The following is a description of a gene set: Genes predicted to be targets of miRBase v22 microRNA mmu_miR_7009_3p in miRDB v6.0 with MirTarget v4 prediction scores > 80 (high confidence targets). from publication Chen Y, Wang X (PMID 31504780) Mouse Gene Set: MIR_7009_3P species: Mus musculus, and this is the list of marker genes: Dclk1, Banf1, Atxn7, Plpbp, Abcc9, Ddx6, Arid1b, St3gal5, Ankrd27, Actr3, 1700025G04Rik (NCBI Gene Id 98629), Gca, Lcorl, Dennd4a, Ythdc2, Ostc, Kcnt2, Arnt, Arhgap30, Taf7l2, Gatc, Dedd, Frem1, Inpp4b, Kmt2a (NCBI Gene Id 214162), Klhl42 (NCBI Gene Id 635102), Naa50, Larp4, Traf2, Il5, Nrp1, Zc3h18, Arrdc4, Slc1a2, Rxrg (retinoid X receptor gamma), Fgf10 (NCBI Gene Id 14165), Ltbp1, Plpp3, Rxfp3, Tiparp, Kcna6, Sp4, Fzd4, C2cd2, Zfp329, Trhr, Tiam1, Uqcrq, Zfp276 (zinc finger protein (C2H2 type) 276), Tatdn1, Lpp, Mlec, Zfp704, Cckbr, Gpr65, Osbpl6, Prpf4, Cox14, Zic3, Tyw3, Rbm43, Zfp953, Zfp819, Lemd1, Cox7a2l, Spred1, Dock3, Rab6b, Cd83, Cntrl, Nabp2, Mmut, Exoc3, Gfod1, Samd4b, Brinp3, Gucy1a1, Mfsd4b5, Celf5, Ak4, C1ql2, Ccnl1, Dyrk1a, Spag9 (sperm associated antigen 9), Clock, Zfp746 (NCBI Gene Id 69228), Parp14, Gli2, Hipk1, Mdfi, Epm2aip1, Vps13b, Tril (TLR4 interactor with leucine-rich repeats), Plxdc2, Rufy2, Eif4h, Trpm3, Clcn4, Zfp518a, Cpeb4 (cytoplasmic polyadenylation element binding protein 4), Magi3, Ano5, Nav1, Acot4, Kdm7a, Ifit1, Timp4, Sgk3 (serum/glucocorticoid regulated kinase 3), Arhgdib, Gabra5, Tut7, Plscr2, Kcnd3, Leprotl1, Runx1t1, Flt4, Tmprss11e, Ston2, Zbtb16, Satb1, Pcmtd2, Tcf20, Rictor, Dennd5b, Gad1, Mogs, Ifi202b (NCBI Gene Id 26388), Apobec1, Cd59a, Timm8a1, Pde1c, Fbxo42, Kcnma1, Adgrg6, Zfp827, Oxnad1, Phc3, Barhl2, Kitl, Rcbtb2, Thrb, Myt1l, Nufip2, Mro, Mob3b, Nfatc4, Prickle2, Dusp7, Dppa1, Add3, Btg2, Fbxw7, Actn1 (NCBI Gene Id 94278), Plppr4, Zmat4, Bach1, Trim37, Sipa1l1, Actl6a, Ptpn3, Trak1, Stim2, Cfap97d1, Nrg3, Lage3, Tex13b, Lancl3, Phip, Ak2, Mcl1, Atxn1, Rmdn3, Chpt1, Tab3, Acly, Mlx, Etv6, Set, Mageb5b, Phka1, Slc30a10, Ncoa7, Sh3pxd2a (NCBI Gene Id 69633), Herc2, Ssbp2, Scamp1, Tnfsf8, Mpped2, Fanca, Elovl6, Dnajc10, Hdgf, Kdm5a, Nipsnap2, Mocs2, Tbc1d2 (TBC1 domain family, member 2), Armc1, Celf3, Tfap2b, Slc37a1, Dut, Ambn, Cab39, Slc7a11, Rab1b, Ccnd2, Lingo2, Pdpk1, Ssh2, Rab11a, Marveld3, Tjp1